Given this list of marker genes SLC4A1APP1, RN7SL151P (NCBI Gene Id 107075319), MIR4474, CDKN2B, H3P31, ENSG00000231460, ENSG00000302201 (NCBI Gene Id 107987059), FTLP4, SMU1, IFNA13, RNU4ATAC15P, IFNA12P, APTX, HSPA8P17, IFNWP18, LINGO2, SUMO2P2, IFNA20P, IFNWP4, SNORA30B, FOCAD, ASS1P12, IFNB1, KCTD10P1, IFNA1, CDKN2B-AS1, IFNK, CDRT15P5, MIR873, EMICERI, SLC25A5P8, IFNWP5, SLC25A6P2, IFNA10, IFNA16, TEK, FOCAD-AS1, TUSC1, IFNNP1, IFT74, CDKN2A-AS1, EQTN, RN7SKP120, LINC01242, DFFBP1, DMRTA1, IFNA8, LINC01241 (long intergenic non-protein coding RNA 1241), REXO6P, KLHL9, IFNA14, TCEA1P4, LINC01243, H3P30, IFNA2, C9orf72, IFNA21, IFNA11P, LAGE3P1, NOP56P2, MIR31HG, RNA5SP280, PLAA, MIR4473, ME2P1, IFNA4, RMRPP5, IFNWP19, LINC01239, MTATP6P30, IFNE, MOB3B, KHSRPP1, CAAP1, B4GALT1-AS1, KRT18P66, IFNA22P, ACO1, MIR491, MLLT3, IFNW1, LRRC19, RPL7AP48, IFNWP2, IFNA17, IFNA5, IZUMO3, IFNA6, SMIM27, IFT74-AS1, RIGI, TUBB8P1, HMGB3P23, SNRPCP1, GARIN3P1, RNA5SP281, UBA52P6, B4GALT1, TAF1L, RNU4-26P, CLIC4P1, DNAJA1, LINC03106, MTAP, IFNWP15, BOLA3P4, ELAVL2, KRT18P36, IFNWP9, ERVFRD-3, MIR31, HACD4, TMEM215, TOPORS, SNORD55, RPL36AP34, MIR876, RBMXP2, RPS26P2, ENSG00000283982, CTAGE12P, MTCO3P30, CDKN2A, RN7SL100P, NDUFB6, IFNA7, here is a description of the gene set: studied in species Homo sapiens Human Gene Set: chr9p21